The following is a description of a gene set: The process in which a relatively unspecialized cell acquires specialized features of a neuron whose cell body resides in the peripheral nervous system. species: Mus musculus Mouse Gene Set: GOBP_PERIPHERAL_NERVOUS_SYSTEM_NEURON_DIFFERENTIATION, and this is the list of marker genes: Nefh, Isl1, Vcam1, Hoxd9, Ntrk2, Pmp22, Hand2, Pou4f1 (NCBI Gene Id 78006), Ascl1, Onecut2, Hoxd10, Tbce, Slc25a46 (NCBI Gene Id 67453)